The following is a description of a gene set: Foxp3+CD4+CD25+ regulatory T (T(reg)) cells are essential for the prevention of autoimmunity. T(reg) cells have an attenuated cytokine response to T-cell receptor stimulation, and can suppress the proliferation and effector function of neighbouring T cells. The forkhead transcription factor Foxp3 (forkhead box P3) is selectively expressed in T(reg) cells, is required for T(reg) development and function, and is sufficient to induce a T(reg) phenotype in conventional CD4+CD25- T cells. Mutations in Foxp3 cause severe, multi-organ autoimmunity in both human and mouse. FOXP3 can cooperate in a DNA-binding complex with NFAT (nuclear factor of activated T cells) to regulate the transcription of several known target genes. However, the global set of genes regulated directly by Foxp3 is not known and consequently, how this transcription factor controls the gene expression programme for T(reg) function is not understood. Here we identify Foxp3 target genes and report that many of these are key modulators of T-cell activation and function. Remarkably, the predominant, although not exclusive, effect of Foxp3 occupancy is to suppress the activation of target genes on T-cell stimulation. Foxp3 suppression of its targets appears to be crucial for the normal function of T(reg) cells, because overactive variants of some target genes are known to be associated with autoimmune disease. Human Gene Set: MARSON_BOUND_BY_E2F4_UNSTIMULATED Genes with promoters bound by E2F4 in unstimulated hybridoma cells. studied in species Mus musculus from publication Marson A, Kretschmer K, Frampton GM, Jacobsen ES, Polansky JK, MacIsaac KD, Levine SS, Fraenkel E, von Boehmer H, Young RA (PMID 17237765), and this is the list of marker genes: FANCG, SF3B5, KIAA0825, FADD, MATR3, SCFD2, MSH3, RPS3A, SBDS, FAAP24, C1orf174, ETAA1 (NCBI Gene Id 54465), DLGAP5, CLIC1, ZFPL1, SPDYA, SPICE1, RIMOC1, MAST1, DCK, SLC16A10, NUDCD1, MAGOH, NDC80, C2CD5 (NCBI Gene Id 9847), CHML, MARS2, CDK19, ZW10, H2AC4, ICE2, RNF41, TACC3, SKA2, MCM4, HMGB3 (high mobility group box 3), NPHP4, KMO, CDCA8, H4C8, VAT1, KIF20A, H2BC18, RAD54L, ASPM, FAM72A, NUP85, SNAPC5, EHD4, MAGOHB, SHCBP1, HSP90B1, HLTF, H2BC3, TUBB, NOTCH1, PPP1R7, NSL1, CNOT9, CENPN, CCDC25 (NCBI Gene Id 55246), TEDC2, CFAP43, CDT1, DZIP3, POLN, GTPBP1, ENKD1, BRD8, SYNGR4, SLC11A2, TBCCD1, TDP1, FIRRM, IFT80, NFYA, ANAPC15, ALMS1 (ALMS1 centrosome and basal body associated protein), AHCTF1, VRK1, HNRNPUL1, C21orf58, HINFP, NUF2, MDM1, TMX1, NEMP1, SENP1, H4C1, CASP8AP2 (NCBI Gene Id 9994), FIP1L1, FBXO5, TRMT2A (NCBI Gene Id 27037), RBMX2, AIMP2, PIF1, RPUSD2, HMMR, CCP110, KIF15, CTNNA3, C1orf159, TIPIN, KIF22, RFC4, STARD6, INIP, KPNA2, TPX2, TTLL5, CGAS, RPS20 (NCBI Gene Id 6224), PCDHGC4, RPN2, PLEKHG2, LSM5, PIGF, CC2D1A, NME7, POLQ, ORC1, ISCU, FERRY3, MCM5, MMACHC, SRSF11 (serine and arginine rich splicing factor 11), KIF2C, HMBS, PYCR3, PAICS, TMEM129, PLK4, SART3, KCTD9, CENPE, CENPL, ARHGAP11A, DCLRE1B, DNAJB11, RNF8, NEMP2, BLM, PPWD1, KIF23, MCM6, UBE2C, PCDHGC5, SLBP, SIAH1, TTC41P, EME1, POLE2, MTBP, FAM110A, C6orf89, PRR11, RAD1, METTL18, HAUS3, DNMT1, NEIL3, MYBL2, DHX36, LIN52 (lin-52 DREAM MuvB core complex component), BTBD10, PPAT (phosphoribosyl pyrophosphate amidotransferase), ERCC6L, PAK4 (p21 (RAC1) activated kinase 4), LY6G5B, H4C6, H3C13, CENPP, POLR2A, BLZF1 (NCBI Gene Id 8548), NUP50, IRF2BP1, ADHFE1, AURKA, H2BC7, RIOK3, FAM229B, FANCM, CDCA7, SAE1, H2AX, UTP3, AP4M1, SGO2, MRNIP, ITGB3BP, NUDCD2, MTAP, ATP5PD, IL23A, MSH6, H3C8, PLAA, UBB, SERBP1, NOLC1, SFPQ, DIAPH3, SYNGR1, BRCA2, MSH2, ARHGAP19, TOP3A, WDR76, PITPNM1, DDX11, NCAPD3, TENT5B, MSH5, JOSD1, REXO5, MZT1, NTAN1, CALU, PAN2, ERI1, H1-3, HELQ, H3C14, NDC1, EXO1, H3-4 (NCBI Gene Id 8290), C9orf43, HJURP, USP5, COX8A, EMC3, EZH2, HELLS, CDCA5, KIF11, E2F1, LSM2, PRIM2, TOP2A, MSN, FBXO48, ABHD10, CEP55, CDK5RAP2, ATRX, CHEK1, SARS2, OSCP1, RIBC1, PRIM1, PIMREG, POLE4, TNFAIP8L1, BORA, IFT27, TMEM258, CCHCR1, CDC6 (cell division cycle 6), RPP30, PELP1, TEDC1, NEU1, BICD2, ECT2, SPC24, MTFR2, TESK2 (testis associated actin remodelling kinase 2), CDCA3, ASF1B, PROSER3, IDH3B, INTS7, TUBE1, XRCC2, KCTD2, CDK1, CEP57, LMBRD2, IQGAP1, DEPDC1B, STOML1 (stomatin like 1), TAP1 (NCBI Gene Id 92050), ANKFY1, FLAD1, PPP1R13L, ZNF438, CDNF, MUTYH, SMPD4, CENPU, RPUSD1, VPS35, CBX1 (NCBI Gene Id 10951), CBX3, TATDN3, TTK, ZNF415, PIGM, H2AZ1, CDCA2, DTL, YIPF5, ZFAND2A, NCAPH, H3C11, STAT1, YME1L1, GOLT1B, NOL8, ZNF689, MCM8, RAB8A, TINF2, RTTN, MFAP1, MRPS12, CXCL10, SGO1, H2AC25, FANCL, BRME1, MRPL27, TTI1, GSTCD, TP53, SRSF10, MRPL18, RAD51AP1, TONSL, XPC, NUP153, RPS6KA5, SKP2, TFAP4, NET1 (neuroepithelial cell transforming 1), PARPBP (PARP1 binding protein), APLF, PRKDC, NFATC2IP, ANP32E, CRNKL1, CSNK2B, UBAP2, CNOT6, HSCB, CD2BP2, RAD51B, ZMYND19, PALB2, CCDC32, LRRC40, RRM1, DERL2, NSMCE1, BUB1 (BUB1 mitotic checkpoint serine/threonine kinase), NUTF2, RAD51, PIAS1, PIDD1, DARS2, BRIX1, NUP133, NEK2, PRIMPOL, CKAP2L, ALKBH2, CCNB2, CLSPN, SHQ1, CEP89, BAG6, SRSF1, KIF18B, INTS12, MELK, SMC1A, SMC2, PML, HSD17B6 (NCBI Gene Id 8630), SASS6, GINS3, RANBP1, MPDU1, DHRS7B, H4C3, MYO9B, NUSAP1, MCPH1, TRAIP, FKBP15, FANCI, GABPB2, BIRC5, RECQL, TCERG1, H1-1, DDOST, TXLNA, PCNT, FAM53C, ALAD, TXNDC12, HAUS6, SLC9A5, TCP1, MYC, HROB, VPS26B, NCBP3, CKS1B, TTC32, PRPF19, HIKESHI, NUBP1, FKBP3, CCNA2, KIF24, SMC4, MXD3 (NCBI Gene Id 83463), H4C9, MED18, NRM, UHRF1, TYW1, DCAF7, CCDC34, H4C4, RPA2, H1-5, XRCC4, SLC31A1, TRIP4, PRPF38A, FH, TOPBP1, NABP2, NXT1, SLC25A22, TMEM241, CRIPT, CDC45, ARMC8, BRMS1L, CEP72, SRSF6, LRRC14, RRS1, TRIM27, DBR1, POLR1G, RAB24, MRPL13, OPA1, H3C15, PEX19, MIS12, MASTL, PMF1, CENPH, SPDL1, HNRNPA2B1, IER5, CASP3, DCTN5, NUP107, ANKRD49 (NCBI Gene Id 54851), HDGFL2, KIAA1143, DSCC1, ALDH6A1, GPANK1, MRPS18C, H2BC5, CCM2, RBL1, LRRC49, ALG8, H2AC7, MIS18A, MAP3K7, CSTF3, KPNB1, PPP1R15B (NCBI Gene Id 84919), POC1A, PSMB9, CFAP61, ING2, DHFR, NHP2, RRM2, CMC2, AP4B1, C5orf22, TMEM167A, MCM7, POLD2, DEPDC1, FAM111A, NBN, PPIL1 (peptidylprolyl isomerase like 1), CDC25C, IPO11, KATNB1, ABRAXAS1, EIF3G, RECQL4, ATP10A, H4C14 (NCBI Gene Id 8370), SMCR8, RAB12, CENPA, SHC1, AGFG2, AIPL1, CCNF, ACD, NUDT2, SKA1, RPRD1B, OGG1, TXNL1, UBXN6, SHMT1, TEKT5, TMEM143, CENPM, SMC3, RPL4, TSEN15, CDC20, TBC1D13, RTEL1, UNG, APOO, INTS3, ESPL1, RACGAP1, CTC1, AIRIM, CENPK, AURKB, POLD3, PPIH, PDZD11, NOP58, NCAPD2, SLC9A1, GTSE1, ESCO2, C6orf47, PRC1, MMUT, SEC11C, TRA2B, LRR1, CENPI, CENPQ, LSM3 (LSM3 homolog, U6 small nuclear RNA and mRNA degradation associated), SMC6, MRE11, KIF4A, PCLAF (PCNA clamp associated factor), EFCAB11, BARD1, FIGNL1, HSPB6, CDC25A, STK35, KATNAL2, ENY2, PTMA (prothymosin alpha), GTF2A1, KNSTRN, MDC1, TXN2, RAMAC, WRAP53, FAM76B, ZNF367, TTC24, TIMM50, HSPA8, STIL, SIVA1, RND2, HSPA14, YLPM1, ZMYM1, PBK, POP7, QTRT2 (NCBI Gene Id 79691), POLA1, NASP, RBMX, HAUS8, RASSF3, KNL1, MCM10, NUCKS1, AK2, GDE1, KCNAB2, TMCO1, ERG28, CHTF18, FEN1, IWS1, PLEKHO2, MND1, C12orf60, MRPL51, CHEK2, ANLN, MTO1, CIT, AAAS, FHOD1, HSPA13 (NCBI Gene Id 6782), USP1, APEX2, IMP3 (IMP U3 small nucleolar ribonucleoprotein 3), POLE3, CMSS1, H2BC13, RNASEH2B (ribonuclease H2 subunit B), PARS2, UFSP2, UBE2S, APOM, GPD2, DGCR8, CDIN1, MYG1, MCM3, RLBP1, DNAJC9, SP9, SETD5, UFD1, H4C16, BRIP1, H2BC11, CFAP36, CIP2A, H2BC6, TOE1, DROSHA, ULBP1, CSTF1, CMTR1 (NCBI Gene Id 23070), C18orf54, CCNG2, RDM1, SCAMP3, RPL3, TRMT6, PLK1, KIFC1, GEMIN6, H2AC8, WBP11, FANCA, TCF3, RSL1D1, TFB1M, OPN3 (NCBI Gene Id 23596), SKA3, CEP128, PMS2, CCDC163, STMN3, CCDC150, RAB11B, MRPL57, GEN1, SPC25, SLC25A10, H3C1, PSMC3IP, INCENP (NCBI Gene Id 56989), DNAJB14, TCF19, COMMD9, PASK, MAD2L1, MNS1, ENTREP3, HASPIN, ZWILCH, ORC6, BTF3L4, BUB1B, NUP37, ABCB6, RANGAP1, OARD1, ITPRIP, TIMM8A, CDK2AP2, CDC7, EXOSC2, SPAG5, C16orf86, SNRNP48, ERI2